Given this list of marker genes Wnt5a, Ido1, Nfkbid, P2rx7, Pdcd1, Pdcd7, Perp, Bcl2l11, Siglec1, Bbc3, Zc3h8, Prelid1, Adam8, Cd47, Trp53 (NCBI Gene Id 22059), Cd274, Ccl5, Tgfb2, here is a description of the gene set: species: Mus musculus Mouse Gene Set: GOBP_POSITIVE_REGULATION_OF_T_CELL_APOPTOTIC_PROCESS Any process that activates or increases the frequency, rate or extent of T cell death by apoptotic process.